Given this list of marker genes HAP1, GDF6, ANK3, ZGLP1, GPR52, RBM3, ITGA7, BRSK2, MLPH, PRR23A, GPR25, ZMPSTE24, BCAP29, S1PR2, NRGN, GNG10, ATOX1, ABHD2, MIPEP, RMRP, AMMECR1, COQ3 (coenzyme Q3, methyltransferase), TTC7B, GUCY2EP, GNG3, TENT5A, COL5A3, LEF1, IRX1, HRK, DNAJB13, PDCD1, PSMG4, P2RX2, RASGRF2, RBX1, TMED7, TNNI2, FAM181A, PITX1, MGMT, DCUN1D5, B4GALNT1, IRF6, SPATA6, RTN4RL1, EIF3H, RTN4R, PDLIM1, ATP1B1, MIR129-1, SSTR2, LCLAT1, ITGA6, VAMP4, CAND2, TRPS1, LMBRD1, VSTM2L, CRIM1, USP28, ESPN, WDTC1, HS1BP3, C2CD4C, ASNS, PDGFB, VEGFA, CAPZB, ETFA (NCBI Gene Id 2108), SSR1, FUNDC2, RPL23A, TANC2, F2RL1, CAMK4, RAB21, RAB8A, MBIP, GTDC1, RNF138, SEMA6C, S100A6, MEGF6, MIRLET7B, DENND2B, TM2D1, ITGA2B, NECTIN4, MYL9, FBXL17, TSC22D2, NXPE1, FAM3D, ZBTB33, RPH3AL, LRRC4B, WNT5B, RPL24, DISP1, TMEM171, NRP1, HMGA2, CARD9, INSYN2B, IER3 (immediate early response 3), NTN4, GAS2L1, BTF3, ATXN10, ACO1, SARS1, FRMD8, FOXH1, CLTA, LTBP3, ACBD6, NIT2, AR, CRB3, ACP3 (NCBI Gene Id 55), CD4, LYSMD2, NPAS1, RGS3, VAPA, GP9, FGF1, PDLIM2, PHGR1, PPL, CAMK2D, ARHGEF15, GGH, MSH3 (NCBI Gene Id 4437), SLC24A3, MTX2, AQP2, COX4I1, NBAS, SHROOM3, RN7SK, ANKRD33 (NCBI Gene Id 60453), PTP4A2, TMEM60, CORT, CORO2B, TANGO6, PRKCB, TSHZ3, TMEM134, LRBA, FAM3C (FAM3 metabolism regulating signaling molecule C), SNORA30, DMRTB1 (DMRT like family B with proline rich C-terminal 1), SH2D4B, MIR17HG, MIR375, CPT1C, ALCAM, PPT2, PLBD2, SLC25A16, KLHL24, TNFRSF12A, PROP1, NOL7, here is a description of the gene set: from publication Smith SM, Moran AP, Duggan SP, Ahmed SE, Mohamed AS, Windle HJ, O'Neill LA, Kelleher DP (PMID 21220698) This study set out to identify global changes in gene expression in MKN45 gastric epithelial cells following 8 hours stimulation with 10 μg/ml lipopolysaccharide (LPS) from the gastric pathogen H. pylori. Microarray analysis was used to compare changes in gene expression between cells treated with 10 μg/ml H. pylori LPS and untreated cells at the same time point. Genes down-regulated in MKN45 cells (stomach cancer): control versus H. pylori LPS. Human Gene Set: GSE25147_UNSTIM_VS_HELIOBACTER_PYLORI_LPS_STIM_MKN45_CELL_DN studied in species Homo sapiens